Given this list of marker genes KCNQ5, ECSIT, PIK3R5, ZNF106, GRB10, TAF5L, VARS1, E2F1, SNORA75, MCM2, PFKL, SLC7A1, IMMP2L (NCBI Gene Id 83943), CRHBP, KIRREL1, WDFY4, RRP9, USP53, HEATR1, SLC1A4, PDZD2, DNA2, ABCB6, ERC1, PKP4, NUP188, THG1L, HLCS, DPH5, GEMIN5, GBP6, TARS2, MYL10, ENTPD6, PDIA6, POLR1B, METTL13, TNKS2, SETD6, MDN1, TTC7A, SREBF1, SND1, FGD2, SCARB1, EIF3I, NME1, NLE1, PGM2, C6orf89, PUSL1, SMO, SRM, IDH2, ADPGK, EGLN1, PRPF31, RPSA, IMPA2, MIR200B, HEMK1, KIF17, CISH, CAD (NCBI Gene Id 790), PPP5C, PGS1, TMEM14C, RPF2, SIVA1, HYOU1, NDRG1, SOCS1 (suppressor of cytokine signaling 1), NMRK1, ABCB5, TXNRD3, PCBP1, EIF4A2, DGCR8, MC1R (NCBI Gene Id 4157), LIG1, EXOSC5, SLC39A14, NXPE3, SLC2A1, UBE2O, ZNRD2, USP31, MTHFD2, MRFAP1, RRP15, DNMT1, CHAC1, CCN3, GFOD2, FAM185A, COX6A1, GPHN (gephyrin, NCBI Gene Id 57566), GSTO1, SF3B3, EWSR1, G3BP1, AHSA1, MDH2, ALKBH5, IPO5, SSBP4, POLE, SOCS3 (NCBI Gene Id 9021), PARP1, PES1, MRPL21, POLD2, AARSD1 (NCBI Gene Id 80755), WDR43, KNTC1, CDC6, COX5A, ABCC1, CDCA7, NT5DC3, BCAT1, CPNE2, NUCB1, AKAP1, LDHA, GNL3, SSR4, PFKP, TFDP1, IPO4, GUK1, MRPS28, ATP5MC1, TBCA, HDLBP, DTNBP1, PWP2, LPCAT4, FUT9, SDHB, PGP, ST3GAL4, MUC16, COX4I1, SNRPD3, PFAS, RRP12, RDH10, PRKCH, RNF26, SLC29A1, MCOLN2, TRUB1, CSF2RB, HSPA9, ISYNA1, PUS7 (pseudouridine synthase 7), EMC4, HIRA, OSGEP, TRIM37, SYNE2, PDK1, XPO5, SLC17A8, THOP1, FAM162A, TIMM10, HSP90AB1, RPN1, GPATCH4, SEMA7A, SLC12A7, RAD51B, LRP8, CRY1, ODC1, LTA, TRA2A, RASGRP1, HK2, PUS1, AVEN, here is a description of the gene set: studied in species Homo sapiens from publication Billmann-Born S, Till A, Arlt A, Lipinski S, Sina C, Latiano A, Annese V, Häsler R, Kerick M, Manke T, Seegert D, Hanidu A, Schäfer H, van Heel D, Li J, Schreiber S, Rosenstiel P (PMID 21335489) Human Gene Set: GSE22611_NOD2_TRANSDUCED_VS_CTRL_HEK293T_STIMULATED_WITH_MDP_2H_DN Genes down-regulated in HEK293 cells at 2h after stimulation by muramyl dipeptide: over-expressing wildtype NOD2 versus control. NOD2 is an intracellular receptor for the bacterial cell wall component muramyl dipeptide (MDP) and variants of NOD2 are associated with chronic inflammatory diseases of barrier organs e.g. Crohn disease, asthma and atopic eczema. It is known that activation of NOD2 induces a variety of inflammatory and antibacterial factors. The exact transcriptomal signatures that define the cellular programs downstream of NOD2 activation and the influence of the Crohn-associated variant L1007fsinsC are yet to be defined. To describe the MDP-induced activation program, we analyzed the transcriptomal reactions of isogenic HEK293 cells expressing NOD2wt or NOD2L1007fsinsC to stimulation with MDP. Importantly, a clear loss-of-function could be observed in the cells carrying the Crohn-associated variant L1007fsinsC, while the NOD2wt cells showed differential regulation of growth factors, chemokines and several antagonists of NF-κB, e.g. TNFAIP3 (A20) and IER3.